The following is a description of a gene set: species: Homo sapiens Apoptosis of cells during Dengue virus infection facilitates virus proliferation and enhances hemorrhagic fever (DHF) and shock syndrome. Apoptosis was demonstrated in liver, brain, intestinal and lung tissues. It is known that the C protein and the NS2B:NS3 complex enhance apoptosis by binding to host factors. On the other hand, early apoptosis of an infected cell is inhibited by NS1, through maintaining autophagy, to allow replication and assembly. Reactome Pathway: Dengue virus modulates apoptosis part of: Dengue Virus-Host Interactions, and this is the list of marker genes: RICTOR, PIK3R4 (phosphoinositide-3-kinase regulatory subunit 4), MAPKAP1, PRR5, RETREG1, BECN1, RPTOR, NFKBIB, DAXX, PIK3C3, NFKBIA, TAOK1, MTOR, RIPK1, MLST8, ATG14